The following is a description of a gene set: Any process that stops, prevents, or reduces the frequency, rate, or extent of leukocyte migration. Mouse Gene Set: GOBP_NEGATIVE_REGULATION_OF_LEUKOCYTE_MIGRATION species: Mus musculus, and this is the list of marker genes: Apod, Cnn2, Cxcl12, Cd200r1 (NCBI Gene Id 57781), Gdf15, Gcsam, Grem1, Plcb1, Slamf8, Ptger4, Emilin1, Hc, Ccl12, Ripor2, Adora1, Ccl21e, Cyp19a1, Rabgef1, Ifnb1, Ada, Stap1, Nf1, Ccl28, Klrk1, Hoxa7, Adtrp, Ccl21d, Cd69, Ccl21f, Mia3, Mif, Cd300a, Akt1, Ccl21a, Cd200, Rin3, Il33, Ccl21b, C5ar2, Bcr, Wasl, Lrch1, Dpp4, Nbl1, Abr, Padi2, Ccl25, Gpr18, Ccn3, Slit2, Il27ra, Dusp1, Mmp28, Tnfaip6